The following is a description of a gene set: Human Gene Set: HP_ABNORMAL_CARPAL_MORPHOLOGY Abnormal carpal morphology studied in species Homo sapiens An abnormality affecting the carpal bones of the wrist (scaphoid, lunate, triquetral, pisiform, trapezium, trapezoid, capitate, hamate)., and this is the list of marker genes: CHSY1, RBM8A, HOXD13, HOXA13, NXN, SETD2, NANS, SALL4, MBTPS1, GNPTAB, MAP3K7, GPC3, SLC10A7, SHOX, PTH1R, LRP4, COMP, XRCC2, COL27A1, TRIP11, BMPR1B, NOTCH2, RECQL4, FLNA, MMP14, BGN, DYNC2LI1, LEMD3, EVC, IDH1, ESCO2, BHLHA9, PRKACA, CANT1, SLC35B2, DDR2, EXT2, XYLT1, GDF5, RSPRY1, ABCC6, ALDH18A1, DYM, MACROH2A1, EXOC6B, KIF22, TRPV4, ATP7A, NOG, EXTL3, SMOC1, GPC4, LMBR1, BPNT2, ROR2 (NCBI Gene Id 621), TBX5, TONSL, FLNB, NIN, POR, SLC35D1 (NCBI Gene Id 23169), SHH, UFSP2, PDE4D, EXT1, RMRP, APC, EIF2AK3, LONP1, WNT7A, PITX1, B3GALT6, GLI1, CBFB, MMP2, SLC34A2, PRKACB, FGFR3, EBP, MATN3, CHST3, FBLN1, PAX3, IHH, ENPP1, COL2A1, MYH3, PIGV, MAFB, FGFR2, EVC2